Given this list of marker genes GLS, DZANK1, ZIC1, MTERF3 (NCBI Gene Id 51001), CRYGB, MED20, INO80B, LRRC75B, PEX12, UGT2B15, KCNG1, CDKN2C, NCKAP1L, ZNF764, ORMDL2, ARHGEF5, ACTN2, HLA-DRB4, ZSCAN32, ARHGAP25, RPP38, PRELID3A, CSRNP2, PNP, DARS2, KIFBP, SRPK2, WDR5B, BICD1, NOMO3, SSBP2, AOC3, TWNK, ZMYM6, CD248, PIP5K1A, CHTOP, TAPT1, KLHL22, LLGL1 (LLGL scribble cell polarity complex component 1, NCBI Gene Id 3996), TM6SF2, PNPLA4, LIPE, TRIM27, MFAP1, ZNF230, RPS16, TUBAL3, AQP6, MUS81, GPR182, UMPS, MTHFS, MAP3K20, CCR3, ING4, PPP2R5B, DNAJA3, ZBTB3, RRAGA, IL23A, IGHG1, RPGR, DLX2, NALF2, ZNF223, NIF3L1, RABEPK, MFAP3, BTN2A1, ZKSCAN4, SIT1, ZSCAN26, SEMA6C, RNF167, SDF2, POU3F1, KRTAP1-3, CKAP5, SNX19, ZNF189, RALGPS1, DST, DDX6, DENND2D, CCDC51, NOP2, CACNG4, ARHGAP35, ERF, SDHAF1, ZNF232, SNX1, HINFP, HPCA, MRPL17, CDH11, JAKMIP2, NDUFA3, PRB4, PTPN21, CYREN, EFNA3, SOHLH2 (spermatogenesis and oogenesis specific basic helix-loop-helix 2), TAF5L, CYP4F12, TIMM8B, PGM3, FXYD3, DMWD, UTP25, WDR3, PPT2, ZNF174, TMEM223, DDX17, ADGRA2, COMMD3, CTF1, MLYCD, ZNF419, HECTD4, HDAC11, FAM234B, GPR171, PLEKHA1, CDX2, CHPF, SYNRG (synergin gamma), RABIF, STAM2, CD52, SLC39A1, PTRH2, DYNLRB1, ZKSCAN3, ID3, UBA52, WFDC1, POGLUT1, ABHD6, NOP10, CRIPT, BOLA1, PAX8, KRT4, PPME1, TEK, FERMT1, POLR3K, H4C3, EXD2, PYY2, DNAL4, BET1, ACSM5, RPA3, EGR2, MRPL35, FEV, TMEM177, ATXN3L, VPS52, HOXA2, SPRR2B, COQ6, CDC123, RNF34, LRRC20, N4BP1 (NEDD4 binding protein 1), PLEKHA4, LAMB4, CBFA2T2, IL11, TGFB3, EPOR, GEMIN6, YIF1B, FAM50B, FOXO4, BBC3, DPF1, ZNF646, CBY1, PUS3, CELSR3, ZNF133, ALKBH1, ITFG2, SPSB1, RTP4, PRB1, MMACHC, GPR52, CZIB, LARGE1, DHX32, here is a description of the gene set: Genes down-regulated in comparison of peripheral blood mononuclear cells (PBMC) from healthy donors versus PBMCs from patients with type 1 diabetes at 4 month after the diagnosis. Human Gene Set: GSE9006_HEALTHY_VS_TYPE_1_DIABETES_PBMC_4MONTH_POST_DX_DN from publication Kaizer EC, Glaser CL, Chaussabel D, Banchereau J, Pascual V, White PC (PMID 17595242) species: Homo sapiens Objective: We hypothesized that type 1 diabetes (T1D) is accompanied by changes in gene expression in peripheral blood mononuclear cells (PBMCs) due to dysregulation of adaptive and innate immunity, counterregulatory responses to immune dysregulation, insulin deficiency and hyperglycemia. Research Design and Methods: Microarray analysis was performed on PBMCs from 43 patients with newly diagnosed T1D, 12 patients with newly diagnosed type 2 diabetes (T2D) and 24 healthy controls. One and four month follow-up samples were obtained from 20 of the T1D patients. Results: Microarray analysis identified genes differing in expression between newlydiagnosed T1D patients and controls at a false discovery rate of 0.05. Changes in expression of interleukin-1β (IL1B), early growth response gene 3 (EGR3), and prostaglandin-endoperoxide synthase 2 (PTGS2) resolved within four months of insulin therapy and were also observed in T2D suggesting that they resulted from hyperglycemia. With use of a knowledge base, 81/genes could be placed within a network of interrelated genes with predicted functions including apoptosis and cell proliferation. IL1B and the MYC oncogene were the most highly-connected genes in the network. IL1B was highly overexpressed in both T1D and T2D, whereas MYC was dysregulated only in T1D. Conclusion: T1D and T2D likely share a final common pathway for beta cell dysfunction that includes secretion of interleukin-1β and prostaglandins by immune effector cells, exacerbating existing beta cell dysfunction, and causing further hyperglycemia. The results identify several targets for disease-modifying therapy of diabetes and potential biomarkers for monitoring treatment efficacy.